Given this list of marker genes BSCL2, CAV1, MTX2, PSMG2, KCNJ6, ZMPSTE24, LMNA, FBN1, here is a description of the gene set: species: Homo sapiens Human Gene Set: HP_GENERALIZED_LIPODYSTROPHY Generalized degenerative changes of the fat tissue. Generalized lipodystrophy